Given this list of marker genes AIPL1, LINC00458 (NCBI Gene Id 100508458), SNHG22, LINC00463, EGFLAM-AS4, SSX2IP, ROM1, PDE6B, ENSG00000254746, RCVRN, LINC00994, MPPED2, MTND1P36, CDHR1, GNGT2 (NCBI Gene Id 2793), PCBP4, MAK, LINC03062, NRL, GNB3, SAMD7, PRPH2, PRKACB, RPGRIP1, KCNV2, ATOH7, ENSG00000225718, ZNF30, SLC6A17-AS1, RAX2, RNU6-1088P, TRIM74, GNAT1, PCARE, PDE6C (phosphodiesterase 6C), NOL4, LINC00457 (NCBI Gene Id 100874179), GRM6 (glutamate metabotropic receptor 6), PDC (NCBI Gene Id 5132), AMER2, MREG, C7orf33, CAPZA1P2, ATP1B2, CASZ1, LRIT3, ENSG00000228044, LOXL1-AS1, PTPN13, GOLGA6GP, ANKRD33B, GNAT2, LINC02932, FRMPD1, PRKN, MARCHF1, TEDC2-AS1, RCBTB1, OPN1SW, CRX, RALGPS2, MPP4, TMX1, SLC6A17, EPB41L2, ARL6, CHRNB4, EGFLAM, LINC02997, CSNK1G2-AS1, MTCO2P15, PLA2G4C-AS1, LHX3, MTND2P26, MTCO1P15, FAM161A, MTATP6P15, PLCH2, IMPG2, PRICKLE2-AS1, USH2A, LRIT2, ST3GAL3-AS1 (ST3GAL3 antisense RNA 1), VXN, SERINC4, OTX2, LEMD1, EYS, TRIM9, TULP1, TMEM244, PCAT4, PRICKLE2-AS3, RHBDL3, PDE6H, RXRG (retinoid X receptor gamma), RPL18P11, FOXO6, ADGRV1, IMPG1, PACSIN1, ANO2, here is a description of the gene set: Marker genes curated from the annotated cluster as represented in the Descartes Human Gene Expression During Development database. species: Homo sapiens Human Gene Set: DESCARTES_MAIN_FETAL_PHOTORECEPTOR_CELLS The gene expression program underlying the specification of human cell types is of fundamental interest. The study authors generated human cell atlases of gene expression and chromatin accessibility in fetal tissues. For gene expression, the study authors applied three-level combinatorial indexing to >110 samples representing 15 organs, ultimately profiling ~4 million single cells. The study authors leveraged the literature and other atlases to identify and annotate hundreds of cell types and subtypes, both within and across tissues. Our analyses focused on organ-specific specializations of broadly distributed cell types (such as blood, endothelial, and epithelial), sites of fetal erythropoiesis (which notably included the adrenal gland), and integration with mouse developmental atlases (such as conserved specification of blood cells). These data represent a rich resource for the exploration of in vivo human gene expression in diverse tissues and cell types. from publication Cao J, O'Day DR, Pliner HA, Kingsley PD, Deng M, Daza RM, Zager MA, Aldinger KA, Blecher-Gonen R, Zhang F, Spielmann M, Palis J, Doherty D, Steemers FJ, Glass IA, Trapnell C, Shendure J (PMID 33184181)